The following is a description of a gene set: Human Gene Set: REACTOME_TP53_REGULATES_TRANSCRIPTION_OF_SEVERAL_ADDITIONAL_CELL_DEATH_GENES_WHOSE_SPECIFIC_ROLES_IN_P53_DEPENDENT_APOPTOSIS_REMAIN_UNCERTAIN studied in species Homo sapiens TP53 regulates transcription of several additional cell death genes whose specific roles in p53-dependent apoptosis remain uncertain, and this is the list of marker genes: TP53I3, RABGGTB, CHM, TP73, TP63, RABGGTA, BIRC5, NDRG1 (N-myc downstream regulated 1), BCL2L14, TP53BP2, TP53, PERP, PPP1R13B, BCL6